Given this list of marker genes KPNA2, TRIM15, KPNA6, NUP153, BST2 (bone marrow stromal cell antigen 2), KPNA3, DYNLT1, CLEC4M, FMR1, CD209, NMT2, here is a description of the gene set: species: Homo sapiens The directed movement of a virus, or part of a virus, into, out of, or within a host cell. Human Gene Set: GOBP_TRANSPORT_OF_VIRUS